Given this list of marker genes PDXK, FKBP1A, RAB31, TNFSF4, FA2H, RCHY1, MTM1, TTC27, PPIF, PTMAP1, VDR, FCGR2A, LETM1, EIF1AX, CENPS, DSE, AGT, SOX4, SLC11A2, FOXC1, CCL1, TSN, ATF5, ISCA1, ME1, XK, N6AMT1, SOX17, PAM, OLR1, ARG2, MED15, KCTD3 (NCBI Gene Id 51133), RAB9A, CA1, THBS1, ZNF571, DHRS2, AKT3, TNIP2, GULP1, NFE2L3 (NFE2 like bZIP transcription factor 3), DNAJC6, POLH, CD200, REL, HEATR3, NOP16, IL5, RPS21, TMEM80, PILRB, SH3BP5, SGPL1, SLC7A11, TLE1, TFDP2 (transcription factor Dp-2), SIRPAP1, NFAT5, NCOA3, CEBPD, ZNF813, UBE2NL, CCNB2, CLIP1, FOXD1-AS1, DOCK10, SLC4A7, AMACR, MSX2, RGS9, GSAP, LINC01482, TTBK2, MSH4, MARCKSL1, CCHCR1, PGAP4, NXN, TMEM30B, NUP58, ABCE1, IL27RA, CA12, ORC6, TNFRSF8, SEC63, CHST1, VCPKMT, SMAD3, PTGER3, ALG9, WWC2, PTPRK, CCDC33, AIRIM, JAK2, TNFAIP3, MARCKS, UBE2B, CEP135, ENSG00000241345, ACSL1, MTF2, NIBAN1, TCF20, SIK2, APOL2, DNAJC16, GALNT12, RELB, IL18RAP, PEX12, ADIPOR2, ZNF140, SPAG1, CITED2, CXCL8, CCL8, BAALC, MAST4, ZNF639, GDF11, GCKR, ZC2HC1A, SCD5, BIRC3, PRSS22, TSFM, SDHAF3, HAMP (hepcidin antimicrobial peptide), RUNX1, FZD3, TNIP1, ETV5, NAP1L1, MIR9-1HG, PELP1, POLR1F, TSR1, MAOA, SKIL, SCN9A, RAB38, TLR1, PDZD2, PTGER4, OPTN, BCL2L11, RUNX2, SDC4, ORAI2, NCKIPSD, FOXO4, ZFPM2, THOC1, TRAF3, MSL3, RAPGEF6, RASGRP1, STAT5A, CCL5, CYB5A, CCR7, FZD6, SMC3, SPAG11B, TNS3, TMEM123, ALCAM, CHST7 (carbohydrate sulfotransferase 7), FSCN1, WT1, PKMYT1, SLC27A2, IGFBP5, IL1RL1, PLPP3, ADAP1, SPHK1, CLGN, RGL1, here is a description of the gene set: Human Gene Set: OKUMURA_INFLAMMATORY_RESPONSE_LPS Genes up-regulated in mast cells (MC) after stimulation with a bacterial lipopolysaccharide (LPS). from publication Okumura S, Kashiwakura J, Tomita H, Matsumoto K, Nakajima T, Saito H, Okayama Y (PMID 12855579) Rodent mast cells (MCs) are reported to play a pivotal role in both innate and adaptive immunity. However, there is so far no evidence that human MCs are involved in innate immunity. We found that a functional Toll-like receptor 4 (TLR4) was expressed on human MCs when it was up-regulated by interferon gamma (IFN-gamma). To systematically explore how human MCs modulate the immune system following TLR4-mediated activation and FcepsilonRI aggregation, we used high-density oligonucleotide probe arrays (GeneChip) to compare the lipopolysaccharide (LPS)-induced gene expression profile with the IgE/anti-IgE-mediated profile in MCs. Both a shared core response, and LPS- or anti-IgE-specific programs of gene expression were observed in MCs. Furthermore, MCs exhibited an antiviral response gene program in response to IFN-gamma, and LPS sustained that expression. Compared with the LPS-stimulated gene expression profile of human peripheral blood mononuclear cells, LPS-stimulated MCs specifically induced a subset of genes that included a Th2 cytokine and chemokines that recruit Th2 cells and eosinophils. These results reveal that human MCs express tailored pathogen- and antigen-specific immune responses and that human MCs may play important roles in innate and adaptive immunity. species: Homo sapiens